The following is a description of a gene set: Human Gene Set: CUI_DEVELOPING_HEART_COMPACT_VENTRICULAR_CARDIOMYOCYTE species: Homo sapiens from publication Cui Y, Zheng Y, Liu X, Yan L, Fan X, Yong J, Hu Y, Dong J, Li Q, Wu X, Gao S, Li J, Wen L, Qiao J, Tang F (PMID 30759401), and this is the list of marker genes: COL6A6, TCF21, CASQ2 (calsequestrin 2), CD34, PDK4, VIM, LUM, UGDH-AS1, ALDOC, TSPO, COL15A1, NIBAN1, RNASE1, FBN1, SHISA9, OGN, SPARCL1, MYL2, COL6A3 (NCBI Gene Id 1293), KLF4, MAB21L3, AHSP, POSTN, MGP, LPP, MMP2, COL5A2, COL3A1, DLK1 (delta like non-canonical Notch ligand 1), ASPN, IL32, CXCL14, GSTT1, HLA-B, COL6A2, ELN, COL1A2, COL5A1, CRYAB, FHL1, PGAM2, COL12A1, COL1A1, ITM2A, RPS4Y1 (ribosomal protein S4 Y-linked 1), DPT, TNNI3, CNOT11, SPARC (secreted protein acidic and cysteine rich), CXCL8, RBP7, HAPLN1, TIMP2, C7, DCN, BANCR, FN1, SRGN, DES, HSPB1, NEFL, COL6A1, LGALS3, PLAC9, LGALS1